The following is a description of a gene set: species: Homo sapiens Human Gene Set: GOBP_MYELOID_CELL_APOPTOTIC_PROCESS Any apoptotic process in a myeloid cell, a cell of the monocyte, granulocyte, mast cell, megakaryocyte, or erythroid lineage., and this is the list of marker genes: NOD2, PIK3CD, CDKN2A, PIK3CB, ARF6, FCER1G, CLEC5A, IRF7, THRA, GATA1, ITPKB, CCR5 (C-C motif chemokine receptor 5), IRF3, NF1, ADIPOQ, GHSR, BAP1, EPO, STAT5B, PLEKHO2, APOH, LIPA, MIF, MIRLET7B, MEF2C, ADAM17, SLC7A11, HCAR2, SELENOS, BCL2, MAEA, SNAI2, CTSL, GAS6, STAT5A, SIRT1, IL6, ANXA1 (NCBI Gene Id 301), FCAR, KITLG, CCL5